Given this list of marker genes Slc8a1, Fut9, Mfsd1, Mpzl1, Phf6, Prickle1, Ssb, Dph6, AI182371, Sema3a, Fam210a, Cacng5, Pip4p2, Trim68, Ppfia2, Zbtb44, Fbxl5, Homer1, Eif5a2, Fli1, Syt13, Topbp1, Dock11, Rnf214, Adamts1, Tceanc, Cep135, Rasef, Kif21a, Glo1, Iqschfp, Mex3c, Dck, G2e3, Ctdspl2, Pfkfb3, Nlrp2, Calca, Lrp1b, Gm5114, Impg2, Mospd1 (motile sperm domain containing 1), Nr4a3, Asxl1, Cdh9, Rab14, Secisbp2l, Ets1, Btg1, Yaf2, Gucy1a2 (NCBI Gene Id 70710), Cttnbp2, Il1rap, Csgalnact2, Rsbn1, Usp6nl, Ino80d, Ctsc, Avl9, Tmem215, Tada2b, Tcerg1l, Zfp608, Akap9, Zfp148, Smo, Tmc8, Lztfl1, Cramp1, Calcr, Lin52, Nkrf, Asah1, Tle1, Ubqln2, Elmod1, Nxt2, Ptprr, Camk2d, Eif1ad, Zfp451 (NCBI Gene Id 98403), Ankhd1, Ankrd1, Herc1, Ttc7, Nectin4, Cfap20, Mllt10, Zfp521, Unk, Pde4dip, Epc2, Tbc1d22b, Alcam, Fbxo33, U2surp, Irs1, Dbx1, Rbbp5, Zfp935, Ralgds, Pcdh7, Lifr, Zfyve16, Marf1, Rbm25, Efnb2, Kank1, Pafah1b1, Diaph2, Erg28, Dlat, Tbx22, Tgfbr3 (NCBI Gene Id 73753), Spock3, Rb1cc1, Phf8, Arid1b, Pcf11, Arhgef10l, Zfp407, Zmym6, Ntrk2, Septin9, Rbm27, Stard13, Gch1, Arhgef11, Rasa2, Yy1, Msx2, Fam76b, Kif3a, Tasp1, Zfp592, Tardbp, Milr1, Tmem151a, Rif1, Dgkd, Kmt2e, Srgap3, Cav2, Schip1, Gria3, Ankrd13c, Gabra1, Zfp704, Kif13a, Gpm6b, Jph1, Gopc, Gm3604, Dlg2, Bdp1, Spin1, Il7, Arhgef7, Otx2, Cmtm8, Prr16, Wtap, Itpr1, Map2, Tubgcp5, Cacna1b, Ccar1, Plxna2, Cks2, Cilk1, Akap6, Gabra2, Ptp4a3, Erf, Pms1, Rgmb, Arl8a, Cwc22, Rock2, Tspan12, Csmd2, Rab10, Ugt2a2, Ppa2, Ppat (phosphoribosyl pyrophosphate amidotransferase), Usp32, Srpk2, Hectd2, Ccser1, Serpinb10, Epb41l1, Lpl, Itch, Zbtb2 (zinc finger and BTB domain containing 2), Zfp280d, Ddx21, Arid4b, Tob2, Ckap2, Mkrn2os, Rab11b (RAB11B, member RAS oncogene family), Epha7, Zfp850, Trhde, Fbxl17, Foxa1, Fosb, Aak1, Stk24, Dennd4a, Eif4ebp1, Arhgap29, Ndnf, Gm4884, Rerg, Zbtb10, Klhl14, Ndst3, Bmpr2, Timp3, Rnf4, Herc6, Rad51d, Sbf2, Rad21 (NCBI Gene Id 19357), Gata3, Nek1, Chek2, Pira12, Fzd8, Calu, L1cam, Necap1, Slc18a2, Eif4enif1, Pik3c2a, Appl1, Lamtor3, Atad1, Skint9, Sfpq, Rictor, Tle4, Foxf2, Bdnf (brain derived neurotrophic factor), Arfgef2, Plag1, Dcun1d4, Kcne4, Serpinb9g, Usp42, Mex3b, Nrf1, Myt1l, Mrc1, Med13, Ank2, Fbxo34, Btaf1, Dip2b, Lrp6, Rngtt, Mast4, Slc17a6, Crebrf, Ulk2, Wdfy3, Mbd4, Alg6, Vps13a, Tagap1, Rab7, Grpr, Gpatch8, Bmp5, Zfp811, Tmem41b, Rnf144a, Lemd3, Fgl2, Elovl5, Itgb1, Ccdc25, Sox21, Kdm6a, Arap2, Kmt2c, Zfp182, Hip1, Pcsk5, Zc3h12c, Dmrta2, Clcn2, Rcn2, Marchf6, Ano4, Ccdc68, Ubxn7, Golph3, Col19a1, Pum2, Rnf38, Tjp2, Sh3rf1, Sft2d3, Xiap (X-linked inhibitor of apoptosis), Rtn1 (reticulon 1), Plekhm3, Egln1, Tmem68, Casz1, Lrrc42, Glipr1l2, Carmil1, Hoxd1, Rgs17, Eea1, Nrbf2, Krt73, Rsf1, Nr1i2, Tab2, Arhgef33, Zfp1008, Klf6, Golim4, Bmp3, Akap13, Wrap73, Ythdc2, Pira2, Prkcd, Khdc4, Myadm, Slc38a2, Lats1, Ifit2 (NCBI Gene Id 15958), Fchsd2, Adamts17, Marchf7, Pitx2, Kif2a (NCBI Gene Id 319353), Trhr, Epha4, Pdik1l, Neto1, Hhip, Pgm2l1, Zfp30, Kcna2, Grm5, Adgre4, Sdad1, B3galt2, St8sia4, Tagap, Gtf2b, Hopx, Etv3, Akain1, Ube2b, Zmat1 (NCBI Gene Id 215693), Casp8ap2, Rab11fip2, Ugt2a1, Mthfd1, Adam23 (NCBI Gene Id 98648), Zfp36l2, Fgfr2, Chrna1, Dusp10, Vcan, Gucy1b1, Mcu, Heatr5b (NCBI Gene Id 72073), Xpo7, Satb2, Ccdc120, Tshz3, Six6, Grsf1, Scn2a, Taok1, Adgrf5, Bmper, Extl2, Kbtbd7, Vkorc1l1, Cstf3, Sh3gl2, Tnrc6c, Gfod1, Evx1, Strbp, Sptbn1, Mef2d, Mphosph10, Sim1, Vps35, Rbfox1, Hook3, Tnfaip8, Ttll7, Ptprb, A630023A22Rik, Dcdc2a, Anks1b, 1700066M21Rik, Olfml2b, Myrf, Trpc1, Nfyb, Syncrip, Ddx10, Hdac4, Ctla4 (NCBI Gene Id 12477), Dnttip2, Tob1, Svil, Rgs4, Dync1li2, Tm9sf3, Rai1, Wdr43, Trim34a, Zwint, Cntfr, Txlng, Styx, Ssbp2, Crybg3, Ptprd, Itga2, Zbtb41, Cflar, Gk, Loxl3, Arl6ip6 (ADP-ribosylation factor-like 6 interacting protein 6), Prr12, Zdhhc21, Lrrc7 (NCBI Gene Id 319537, leucine rich repeat containing 7), Evx2, Cul3, Runx2, Rab11fip3, Edil3, Nefl, Rnf111, Vps13d, Fhip1b, Sdcbp, Abcb1b, Otud4, Sema4b, Fech, Med14, Qrfprl, Camsap2, Cebpg (CCAAT/enhancer binding protein gamma), Cd209a, Araf, 1110059G10Rik, Tmem196, Spag9, Zbtb11, Cnbp, Tfg, Lrp8, Pea15a, Lix1l, B3galt1, Prpf4b, Uty, Zic1, Dnali1, Rap1gap2, Dleu7, Far1, Btbd3, Map7d2, Znrf3, Psd3, Rev3l, Pmp22, Spred1, Cxcl16, Mapk1, Phrf1, Mtmr6, Tnfrsf11b, Slc4a7, Gpcpd1, Hivep1, Fgf4, Spty2d1, Naa20, Tmtc2, Zswim6, Dennd2b, Hycc2, Clec12a, Set, Cask, Lhx8, Apobec3, Spry1, Kcnma1, Cxcl5, Gm15881, Lin9, Nr3c2, Mbnl2, Myo9a, Gm5592, Ppm1h, Mrpl39, Ino80, Nectin3, Osbpl8, Nom1, Sh3gl3, Eml6, Zrsr2 (NCBI Gene Id 97588), Usp25, Ccnc, Fgd4, Ube3c, Nup35, Hmgxb4, Emc7, here is a description of the gene set: from publication Chen Y, Wang X (PMID 31504780) studied in species Mus musculus Genes predicted to be targets of miRBase v22 microRNA mmu_miR_467b_3p, mmu_miR_467c_3p, mmu_miR_467d_3p, mmu_miR_467e_3p in miRDB v6.0 with MirTarget v4 prediction scores > 80 (high confidence targets). Mouse Gene Set: MIR_467B_3P_MIR_467C_3P_MIR_467D_3P_MIR_467E_3P